Given this list of marker genes Eqtn (equatorin, sperm acrosome associated), Zp3, Rims1, Rab3a, Hyal3, Stxbp1, Unc13b, Syt6, here is a description of the gene set: Mouse Gene Set: GOBP_ACROSOMAL_VESICLE_EXOCYTOSIS The calcium ion regulated exocytosis which results in fusion of the acrosomal vesicle with the plasma membrane of the sperm as part of the acrosome reaction. species: Mus musculus